Given this list of marker genes CDH3, SOX18, RIPK4, MBTPS2 (membrane bound transcription factor peptidase, site 2), BRAF, JUP, UROS, PI4KA, RECQL4, CWC27, MAP2K2 (NCBI Gene Id 85511), HOXC13, DSP, ANAPC1, LMNA, EDARADD, AXIN2, HR, TTC7A, ZMPSTE24 (zinc metallopeptidase STE24), ODC1 (NCBI Gene Id 4953), GJB6, KRAS, LTV1, PKP1, UBE3B, RNU12, ALX1, KRT85 (NCBI Gene Id 3891), TWIST2, FRAS1, POLR3A, SMARCA2, EDA, GJA1, here is a description of the gene set: Human Gene Set: HP_ABSENT_EYEBROW Absent eyebrow species: Homo sapiens Absence of the eyebrow.